Given this list of marker genes GOLGA8N (golgin A8 family member N), ETV7, KLHDC7B, ZBTB11-AS1, EREG, P2RY6, TTLL1, TAMALIN, TMOD4, OSM, LINC01888, CD40, SIK1, G0S2, here is a description of the gene set: Genes down-regulated in monocyte 7d vs 0d in adults after exposure to 2011-2012 trivalent inactivated vaccine (A/California/7/09 (H1N1), A/Perth /16/2009 (H3N2), B/Brisbane/60/2008), time point 7D. Comment: Down-regulated DE RNA transcripts (down >= 1.5x) shared between both TIV-vaccinated donors Systems biology is an approach to comprehensively study complex interactions within a biological system. Most published systems vaccinology studies have utilized whole blood or peripheral blood mononuclear cells (PBMC) to monitor the immune response after vaccination. Because human blood is comprised of multiple hematopoietic cell types, the potential for masking responses of under-represented cell populations is increased when analyzing whole blood or PBMC. To investigate the contribution of individual cell types to the immune response after vaccination, we established a rapid and efficient method to purify human T and B cells, natural killer (NK) cells, myeloid dendritic cells (mDC), monocytes, and neutrophils from fresh venous blood. Purified cells were fractionated and processed in a single day. RNA-Seq and quantitative shotgun proteomics were performed to determine expression profiles for each cell type prior to and after inactivated seasonal influenza vaccination. Our results show that transcriptomic and proteomic profiles generated from purified immune cells differ significantly from PBMC. Differential expression analysis for each immune cell type also shows unique transcriptomic and proteomic expression profiles as well as changing biological networks at early time points after vaccination. This cell type-specific information provides a more comprehensive approach to monitor vaccine responses. Human Gene Set: HOEK_MONOCYTE_2011_2012_TIV_ADULT_7DY_DN from publication Hoek KL, Samir P, Howard LM, Niu X, Prasad N, Galassie A, Liu Q, Allos TM, Floyd KA, Guo Y, Shyr Y, Levy SE, Joyce S, Edwards KM, Link AJ (PMID 25706537) studied in species Homo sapiens